Given this list of marker genes NME4, STC1, RHOBTB3, NOC4L (NCBI Gene Id 79050), ATP5F1D (ATP synthase F1 subunit delta), SEMG2, RAG2, SMOX, TTK, KMO, TRIM28 (tripartite motif containing 28), ZNF629, DSN1, NTRK2, MRE11, MCM7, MC4R, CD33, HMGB3P1, RAN, PCDHB12, GLUD1, PXMP2, AEBP1, CTNND1, GMNN, YBX1, GTF2A1, PIEZO1 (piezo type mechanosensitive ion channel component 1 (Er blood group)), SETBP1, REPIN1, SERPING1, S100A11, SLC43A3, KLHL11, HSPA6, GLO1, ZSWIM1, KPNA2, BTG3, MRPL4, HUS1, ATP2A1, DAB2, CCL17, HOXC8, MTHFD1, AHSA1, FADS1, NAA50, IL7, POLD2, ARHGAP6, NELFE, VAT1, TRIO, TRAIP, H2AZ1, CKS1B, EIF4E, TFPI, TEX13A, ARHGAP5, TCEAL9, TNFRSF21, ENO1, SKP2, TNFRSF10B, KIF14, HSPB8, RCAN1 (regulator of calcineurin 1), GINS4, RFC4, NDUFB3, UBE2J1, FAM53B, MDFIC, IFRD2, WWOX, NDC80, DDR1-DT, EIF2B3, FMO2, POLD1, TYROBP, GLUD2, YWHAQ, RUFY3, GINS3, SLC6A6, MIR622, PRKDC, MSRB2, STK32B, CLIC4, GRIN2C, MEF2C, HIRIP3, DCLRE1B, MCM3, BRIP1, BAG2, POLQ, PSMD8, MCHR1, ADISSP, CLDN16, RUBCNL, CD99, KDM1A, H1-0, TFDP2, SHCBP1, SERP1, LDHC, MLF2, PSMB2, CDX2, TAF4B, SMS, MED20, IMPG1, VAC14, NDST1, ETV5, ZNF787, HLA-DRA, DNTT, CCNA2, CBFA2T3 (CBFA2/RUNX1 partner transcriptional co-repressor 3), SNRNP25, GSTZ1, SNRPA1, H4C1, PALLD, AKR1C1, RAC1, CLUH, SEC13 (SEC13 homolog, nuclear pore and COPII coat complex component), SPPL2B, CKS2, PURG, TNFSF9, PSMA6, ERN1, RFC3, WEE1, GALNT14, TPGS2, CDCA3, ATAD5, SKA1, KLHDC3, POLA1, HCFC1, SNHG17, CNTNAP1, CLCA2, SLPI, RHPN1-AS1, FIRRM, PLAUR, SHQ1, HSD17B6, GLRX2, BEGAIN, GALNT2, CCR8, CCNO, RTL10, FGGY, PTGES3, CLCN5, HTR1F, TOP2A, RPL6, IMPA2, FOLH1, INTS14 (NCBI Gene Id 81556), EGLN3, CYBRD1, MTCH2, ABI3BP (NCBI Gene Id 79859), PTPRM, CIT, B4GALT6, DDX11, SOD2, EDNRA, MORF4L2, CHAF1B, NSDHL, WNT2, NOL7, HOXB9, ANP32A, ZNF195, SNRPF, BSPRY, CYC1 (NCBI Gene Id 1537), here is a description of the gene set: from publication Hervas-Stubbs S, Riezu-Boj JI, Gonzalez I, Mancheño U, Dubrot J, Azpilicueta A, Gabari I, Palazon A, Aranguren A, Ruiz J, Prieto J, Larrea E, Melero I (PMID 21108462) IFN alpha mediated gene expression pattern. The effect of IFN alpha on human CD8 T cells responding to antigen (signal 1) and costimulatory signals (signal 2) provided by beads coated with anti-CD3 and anti-CD28 mAbs. This analysis examined the effects of IFN alpha on human CD8 T cells responding to antigen (signal 1) and costimulatory signals (signal 2) provided by beads coated with anti-CD3 and anti-CD28 mAbs. Magnetically sorted untouched CD8+CD45R0- T cells from three different donors were unstimulated or stimulated with IFNa2b or with anti-CD3/CD28 Beads alone or along with IFNa2b or IFNa5 for 48 hours. Individual mRNA samples were analyzed using HG-U133A 2.0 array gene chips. species: Homo sapiens Genes down-regulated in CD8 T cells stimulated by IFNA2 versus CD8 T cells stimulated by IFNA5 and activated by anti-CD3 and anti-CD28. Human Gene Set: GSE17301_IFNA2_VS_IFNA5_STIM_ACD3_ACD28_ACT_CD8_TCELL_DN